The following is a description of a gene set: Intraflagellar transport studied in species Homo sapiens Human Gene Set: REACTOME_INTRAFLAGELLAR_TRANSPORT, and this is the list of marker genes: IFT172, DYNC2I1, DYNLL2, TUBA1C, DYNLT5, TUBA3D, IFT56, IFT88, DYNLRB2, IFT80, TUBB6 (NCBI Gene Id 84617), WDR19, TRIP11, IFT70B, TRAF3IP1, IFT52, KIF3C, IFT122, DYNLT2B, DYNC2LI1, IFT140, CLUAP1, KIF17, KIF3B, KIF3A, IFT57, DYNLL1, IFT43, IFT25 (NCBI Gene Id 51668), TUBA1A, DYNC2H1, TTC21B (tetratricopeptide repeat domain 21B), TUBB2B, TUBB2A, IFT74, DYNC2I2, IFT46, IFT81, TUBB4B, IFT27, TUBA1B, TUBB4A, DYNLRB1, TNPO1, KIFAP3, IFT22, TUBA4A, TUBA3C, TUBB1, IFT20, DYNLT2, IFT70A, TUBB3, WDR35 (WD repeat domain 35)